Given this list of marker genes Hs3st4, Extl1, Gpc1, Xylt2, B3gat3, Naglu, Sulf1, Xylt1, Ext2, Glce, Hs6st3, Sgsh, Hs3st2, Ctsl, Tcf7l2, Hs6st2, Ndst2 (N-deacetylase/N-sulfotransferase (heparan glucosaminyl) 2), B3galt6, Gusb, Hs3st5, Gns, Sulf2, Ndst3, Tm9sf2, Hs3st1, Hpse, Hs3st3a1, Hs2st1, Extl3, Idua, Hs3st3b1, Ctnnb1, Pxylp1, Ugdh, Vangl2, Ids (iduronate 2-sulfatase), Hs3st6, Dse, Ndst1, Hs6st1, Ext1, Ndst4, Slc35d2, Lipc, Hgsnat, here is a description of the gene set: species: Mus musculus Mouse Gene Set: GOBP_HEPARAN_SULFATE_PROTEOGLYCAN_METABOLIC_PROCESS The chemical reactions and pathways involving heparan sulfate proteoglycans, which consist of a core protein linked to a heparan sulfate glycosaminoglycan. The heparan sulfate chain is composed of the repeating disaccharide unit beta-(1,4)-N-acetyl-D-glucosamine-alpha-(1,4)-hexuronic acid, the former being either sulfated or deacetylated on its amino group as well as sulfated on one of its hydroxyl groups, and the latter being a mixture of sulfated and nonsulfated D-glucuronic and L-iduronic acids.